Given this list of marker genes Klhl40, Rpl6, Smpx, Fhl2, Ppp1r12a, Sptbn1, Mybpc2, Myl7, Hdac4, Myom2, Ryr2, Mybph, Kctd6 (potassium channel tetramerisation domain containing 6), Ppp2r5a, Unc45b, Dst, Mybpc1, Lmod2, Obscn, Nbr1, Cmya5, Rpl17, Myom1, Aldoa, Hspb1, Trim63, Myh1, Kat2b, Myl2, Slmap, Myl4, Lrrc39, Cryab, Klhl41, Myh2, Mybpc3, Rpl15, Ank1, Atp2a1, Ank2, Ttn, Smtnl1, Rpl4, Myl3, Myom3, S100a1, Ppp1r12b, Rpl7, Lmod3, here is a description of the gene set: The dark-staining region of a sarcomere, in which myosin thick filaments are present; the center is traversed by the paler H zone, which in turn contains the M line. Mouse Gene Set: GOCC_A_BAND species: Mus musculus